The following is a description of a gene set: studied in species Mus musculus Mouse Gene Set: ZBTB7B_TARGET_GENES from publication Yevshin I, Sharipov R, Kolmykov S, Kondrakhin Y, Kolpakov F (PMID 30445619) Genes containing one or more binding sites for (Zbtb7b) in their promoter regions (TSS -1000,+100 bp) as identified by GTRD version 20.06 ChIP-seq harmonization., and this is the list of marker genes: Sertad1, Gng5, Ypel2, E130308A19Rik, Gm7160, Bcl2, Copg2, Fasn, Dnah17, Bcl7c, Mir6973a, Nek7, Nedd1, Tmem240 (NCBI Gene Id 633976), Pprc1, Slc25a16, Polr1d, Pdcd2l, Dvl1, Ccnd2, Pds5a, C1qtnf6, Bcl9, Nkiras2, AI480526, Smc2, Ccdc88c, Dcaf7, Gnas, Tanc2, Arhgap12, Ssbp3, Ubtd2, Mgll, Kif3c, Tlk2, Prdx5, St6galnac4, D430040D24Rik, Gfi1, Gapvd1, Tbc1d1, Iqsec1, Stat5b, 4932412D23Rik, Upp2, R3hcc1, Pias3, Crot, Dnajb5, Dleu2, A430005L14Rik, Ino80dos, Man2a2, Tfeb, Rnf157, Dhx35, Zic2, Ppp1r10, Gm26839, Gm11423, Ankrd13a, Il2ra, 6530402F18Rik, Mat2a, Nabp2, Fbxo46, Rbbp6, Nyap1, Nnt, Nedd4l, Rnf103, Akirin1, Epb41l4b, Zfp422, Trib2, Mapk9, Atf1, Elovl7, Ubl3, Cbx3, Cyb561d1, Gatad1, 1700016A09Rik, Twf2, Pbx2, Gm15850, B230112G18Rik (NCBI Gene Id 77842), Itpr3, Gbp2, Anp32a, Zbtb11os1, Mir142hg, Limk2, Zfand4, Ddb2, Golm2, 4933439C10Rik, Zfp326, Ddit3, 1810014B01Rik, Ikzf2, Tmem9b, Sh3bp1, Nsun6, Furin, Erf, Cul1, Nr2f6, Stk3, Spag7, Gm10517, Rras, E230001N04Rik, Pimreg, Zfp251, Cul3, Pisd-ps2, Glipr2, Odc1, Gm11999, Aldh2, Zfp740, 1810021B22Rik, Bltp2, Mbtd1, Hnrnpa2b1 (heterogeneous nuclear ribonucleoprotein A2/B1), Tfdp2, Odf2l, Cdk19os, Desi2, Socs5, Relt, Nt5c2, Mettl6, Prkd3, Uqcrh, Gm20109, Zfp652, Zyx, 9130213A22Rik, Ctcf, Zfc3h1, Cks1b, Bhlhe40, Fbxo30 (F-box protein 30), D930048N14Rik, Ptpra, Tns1, Jade1, F730035M05Rik, Vamp4, Wiz, Rest, Pigz, 1700028I16Rik, Gm10433, Dtwd2, Tnfrsf9, Reps1, Baz1b, Vars2, Kmt2b, Fchsd2, Tmem62, Cdc27, Fnip1, Tmem263, Prkag2, Zfp319, Dusp2, 1500009L16Rik, Gm11346, Arpc5l, Ube2q1, Trim28, Mir3569, Minpp1, Maz, 4930519P11Rik, Pafah1b3, Mmaa, Lpgat1, 4930412M03Rik, Rom1, Atosa, 2810408A11Rik, Enah, Rnf14, Mink1, Cnot7, 2900005J15Rik, Get4, Micall1, Tpm3, Zc3h10, Foxo6, Tmem198, Ints12 (integrator complex subunit 12), Mtif2, Gm11613, Prkaa1 (protein kinase, AMP-activated, alpha 1 catalytic subunit), Snx30 (sorting nexin family member 30), Bag2, Myl4 (NCBI Gene Id 17896), Pik3r1, Epb41l2, Tlx3, Kdm2b, Fkbp1b, Foxj3, Gm9484, Chpf, Pmepa1os, Zbtb1, Zcchc2, Slc25a4, Rusc1, Ccdc88b, Ctbp1, Ldlrad4, Trrap, 4930417H01Rik, Scmh1, Uxs1, Brwd1, Numbl, Ube2e1, Midn, Tent5c, Ubn2, Ppm1m, Msl1, Prr12, Atrnl1, Glul, Tap2, Patl1, Frs3, Dennd1b, Gm11696, Cltb, Park7, Nr4a3, Gm20544 (predicted gene 20544), Nipsnap2, Cbln3, Slc12a4, Rab8a, Xpot (exportin, tRNA (nuclear export receptor for tRNAs)), Hivep2, Aamdc, Yeats2, Nisch, Teddm2, Cd164, Catsper2, Tmem256, Slc30a4, Gm16283, Lamtor2, Gnptab, Eri2, Lasp1, Faap20, 1810010H24Rik, Ppp1r18, Hspd1, Hscb, Thra, Gm12925, Gtpbp2, Fmnl3, Dram1, Slain1, Spata1, Gm4890, Mef2d, Eml2, Rmnd5a, Arl5b, Ube4b, Klhl15, Foxp1, Saraf, Vegfb, E030042O20Rik, Snx11, Sp3, Fosl2, Nfe2l2, A930024E05Rik, Ccm2, Rexo5, AA474408, Zmym4, Hsp90ab1, Cdyl2, Ell3, Ptgr3, Hspe1, Efr3a, Spata24, Med13l, Cilk1, Prr14, Rufy4, Agfg1, Cic, Gpr146, Chchd7, Arl4c, Dusp19, Fut8, Tbl1x, Vasp, Acot7, Igsf9, Nsmaf, D16Ertd472e, Dnmt3a, Gstcd, Gnaq, Slc16a1, 4930467K11Rik (RIKEN cDNA 4930467K11 gene), Echdc1, Celsr1 (NCBI Gene Id 57075), Vav2, Thap2, Celf1, Dusp22, Fzd5, Brd2, Hoxa11os, 0610010K14Rik, Azin1, Sec24b, Wdr43, Tbc1d10b, Avpi1, Fam171a2, Socs7, Chmp2a, Lsm1, Taf11, Phf21a, Cyrib, Parp6, Setd1b, Bmp2k, Mrps6, Coro1a, 5330439K02Rik, Gm5432, Zdhhc12, Ubtf, Med21, 1500002F19Rik, Zfp580, Zfp524, Stk38l, Pcgf3, Zswim6, Mfsd9 (major facilitator superfamily domain containing 9), 2410022M11Rik, Zfp605, Nr6a1, Dgkz, Podnl1, Capn2, Ugp2, Krba1 (NCBI Gene Id 77827), AI597479, Isca1, Tmsb10, Notch2, Hnrnpk, Ywhaz, Lrrc75a, Ptpn6, 4732491K20Rik, Cd44, Efcab2, Wtap, Eaf1, 4930515G01Rik, Tnk2, Eif1b, Zfp771, Snx9, Trp53bp2, Kpnb1, Gm29257, Pfkfb3, Letmd1, Lnx2, Chmp3, Eml3, Calm3, Gpat4, Pou2f2, 4632404H12Rik, 2010110E17Rik, Rdm1, Myo1c, Nlgn2, Srpk2, Zfp341, H3f3a, Eef2kmt, Tgfbrap1, Slc43a2, Ldb1, Smad4, Plekha2, Rasgrp2, Hectd1, Glis2, Ppp2r5a, Anks1, Zbtb14, Tmem19, Syngr1, Tmem11 (NCBI Gene Id 216821), Ptp4a2, Foxp4, Cip2a, Cacnb3, Chek2, Dmwd, Evi2b, Emp3, Zbtb8os, Aftph, Galnt12, Zbtb32, Bcl3, Slc35a1, Rnf220, Il12rb1, Kcnq5 (NCBI Gene Id 77687), Trabd, Pld3, Hivep1, Miga1, Pmepa1, Zftraf1, Rhog, Med30, Edc3, Taf5l, Fhl3, Mex3a, Trim24, Patz1, Trmt112, Fiz1, Smim27, Slc25a29, Ubqln4, Agbl5, Rassf5, Plag1, Zmym5, Nup35, Ccdc102a, Znrf1, 4930412F09Rik, Mbd3, Tgfb1, Pan3, Bag6, Stag1, Cat, Zfp383, C1galt1, Selenok, Ssc4d, Bahd1, Atp8b2, Pogz, Rap2a, Cyth4, Gm24000, Uimc1, Plin3, Rel, Gm15567, Ntng2, N4bp2l1, Prrc2b, D630045J12Rik, 2500004C02Rik, Mir330, A730061H03Rik, Tpst1, Frg2f1, Art3, Atxn2, Slc39a3, Bcar3, Apobec3, Gm11175, Sdcbp, N4bp3, Leprotl1, Dnaaf4, Nedd4, Gm40190, Nckap1, Dbil5 (diazepam binding inhibitor-like 5), 1500002C15Rik, Mir345, Mir7687, Mcm3ap, Cisd2, Hmgb1, Zbtb7a, Atp13a3, Gmfg, Fancc, Stx1a, Zfp217, Mettl9, Hsf2, Rcbtb2, Skp1, Tex261, Ctdspl2, Kmt2c, Zbtb25, Tgif2, Gpd2 (NCBI Gene Id 99372), Fhl4 (NCBI Gene Id 14202), Plec, Mmgt2, 2410002F23Rik, Mettl21a, Washc1, Bambi, Rbbp4 (NCBI Gene Id 19646), Zfta, Unkl, Smc2os, Dyrk1b, Msi2, Tcf12, Bbc3, Wfdc3, Ikzf1, Zfp652os, Gm16630, Srsf9, Far1, Sipa1l1, Neurl4, Jazf1 (NCBI Gene Id 231986), Ankrd60, Slfn10-ps, Gm26511, Rufy3, Trerf1, Lncpint, Wac, Crlf3, Lrp6, Arid2, Eeig2, Rreb1, Samd1, Asah1, Gm15545, Smpd1 (NCBI Gene Id 20597), Prickle4, Hic1, Mrps18b, Zfyve9, Eif4e2, Gpatch8 (G patch domain containing 8), Fbxo21, Dnajc7, Rara, Mageb3, Rasgrp1, Pdia3, Cebpb, C030037D09Rik, Oip5, Prkag1, Zfp786, Helz, Stat5a, Csnk1a1, 1700025G04Rik, Gm17509, 5730471H19Rik, Lag3, Nelfa, Senp6 (SUMO/sentrin specific peptidase 6), St3gal3, Rcc2, 1700052K11Rik, Plekhg2, Acvr1c, Stk24, Rora, Ppil1, Ltb, Fbxo11, Ugcg, Fam193a, Sik2, Ric1 (NCBI Gene Id 77643), Usf3, Pmpcb, Caprin2, Gramd1a, Gemin4, Sh3glb2, A930007I19Rik, Vps37a (vacuolar protein sorting 37A), Dcaf11, Plscr3, Gm26901, Sh3rf1, Trim41, Ep300, B3glct, Cblb, Kif7, Zdhhc8, Ccng2, Gm2453, Ulk3, Swap70 (SWA-70 protein), Terf2, Suz12, Perp, Kbtbd7, Cep85l, Heg1, Spred1, Sfr1, Acvr1, Usb1, Gm32999, Phlda3, Cdk2ap1, Tubb5, Smarca4, Mir7075, Ank, Hmg20a, Dnaaf9, Cbl, Chst11, Tspyl3, Tmem158, Memo1, Fnta, Macf1, Gm26812 (predicted gene, 26812), Dnttip1 (deoxynucleotidyltransferase, terminal, interacting protein 1), Dicer1, Atp2c1 (NCBI Gene Id 76638), Utp18, Nkg7 (natural killer cell group 7 sequence), Cdc42se1, Itpka, Gm12474 (NCBI Gene Id 547224), Sp3os, Dzip3, Cux1, Gne (NCBI Gene Id 69688), Rps6ka1, Erbin, Homer3, Zfp69, Camk2g, Rpgr, Flot1, Pygl, Urb2, Sec62, Kif21b, Pomk, Npepl1, Slc5a3, Lrrfip1, Rap2c, Zbtb34